The following is a description of a gene set: Genes up-regulated in a mouse model of heart disease whose expression reverted to normal by silencing of MIR21 microRNA. MicroRNAs comprise a broad class of small non-coding RNAs that control expression of complementary target messenger RNAs. Dysregulation of microRNAs by several mechanisms has been described in various disease states including cardiac disease. Whereas previous studies of cardiac disease have focused on microRNAs that are primarily expressed in cardiomyocytes, the role of microRNAs expressed in other cell types of the heart is unclear. Here we show that microRNA-21 (miR-21, also known as Mirn21) regulates the ERK-MAP kinase signalling pathway in cardiac fibroblasts, which has impacts on global cardiac structure and function. miR-21 levels are increased selectively in fibroblasts of the failing heart, augmenting ERK-MAP kinase activity through inhibition of sprouty homologue 1 (Spry1). This mechanism regulates fibroblast survival and growth factor secretion, apparently controlling the extent of interstitial fibrosis and cardiac hypertrophy. In vivo silencing of miR-21 by a specific antagomir in a mouse pressure-overload-induced disease model reduces cardiac ERK-MAP kinase activity, inhibits interstitial fibrosis and attenuates cardiac dysfunction. These findings reveal that microRNAs can contribute to myocardial disease by an effect in cardiac fibroblasts. Our results validate miR-21 as a disease target in heart failure and establish the therapeutic efficacy of microRNA therapeutic intervention in a cardiovascular disease setting. studied in species Mus musculus from publication Thum T, Gross C, Fiedler J, Fischer T, Kissler S, Bussen M, Galuppo P, Just S, Rottbauer W, Frantz S, Castoldi M, Soutschek J, Koteliansky V, Rosenwald A, Basson MA, Licht JD, Pena JT, Rouhanifard SH, Muckenthaler MU, Tuschl T, Martin GR, Bauersachs J, Engelhardt S (PMID 19043405) Mouse Gene Set: THUM_MIR21_TARGETS_HEART_DISEASE_UP, and this is the list of marker genes: Rcan1, Aspn, Ltbp2, Col1a2, Col5a2, Eln, Ccn5, Apod, Crlf1, Lum, Tgfb3, Nmrk2, Igfbp7, Col1a1, Postn, Bgn, Svep1, Lox